Given this list of marker genes CKB, POTEE, ZNF148, DYNLL1, PADI2, ATP5PB, MBP, RAD1, LDHA, CALM2, GLUD1, NDRG2, CALM3, CDC42, SYNGR3, CCDC14, MAG, SIRT2, FGF9, ZNF430, NDUFS3 (NADH:ubiquinone oxidoreductase core subunit S3), CALM1, FGF2, ACTB, H2BC12L, YWHAE, YWHAQ, PLP1, RHOA, CASP5, GNB4, INA, CNP, MAPKAP1, SUDS3, TTBK1, BASP1, SEC16A, MAOB, COX6B1, SYPL2, HSPA5, ATP5PF, G6PD, YWHAH, S100A1, here is a description of the gene set: studied in species Homo sapiens The progression of the substantia nigra over time from its initial formation until its mature state. The substantia nigra is the layer of gray substance that separates the posterior parts of the cerebral peduncles (tegmentum mesencephali) from the anterior parts; it normally includes a posterior compact part with many pigmented cells (pars compacta) and an anterior reticular part whose cells contain little pigment (pars reticularis). Human Gene Set: GOBP_SUBSTANTIA_NIGRA_DEVELOPMENT